The following is a description of a gene set: species: Homo sapiens The biological process whose specific outcome is the progression of a neural nucleus from its initial condition to its mature state. A neural nucleus is an anatomical structure consisting of a discrete aggregate of neuronal soma. Human Gene Set: GOBP_NEURAL_NUCLEUS_DEVELOPMENT, and this is the list of marker genes: RAD1, ZNF430, CALM3, G6PD, SUDS3 (NCBI Gene Id 64426), NFIB, FGF2, CNP, HOXB2, LARGE1, GNB4 (NCBI Gene Id 59345), ATF2, TTBK1, SYNGR3, CALM2, RHOA, POTEE, KCNE1, YWHAQ, MAG, CCDC14, CDC42, CHRNB2, CASP5, KIRREL3, NKX2-1, HOXB1, COX6B1, H2BC12L, ASCL1, DYNLL1, PLP1, KCNC2, INA, SIRT2, NDRG2, HSPA5, BASP1, ZNF148, S100A1, SEC16A, ARX, CALM1, YWHAE, SEC24B, PHOX2A, YWHAH, MAPKAP1, NDUFS3, FGF9, FOXP2, ACTB, PADI2, MBP, BCL2, PHOX2B, GLUD1, LDHA, MAOB, CDK5R1, CKB, SCRIB, PITX2, ATP5PF, ALDH1A3, SYPL2 (NCBI Gene Id 284612, synaptophysin like 2), CDK5R2, KCNC1, ATP5PB